Given this list of marker genes MAP7, SNRPF, DCTPP1, HLA-DPA1, CIITA, H2BC6, ADAM28, RPSA, ITGB7, SSR1, DAB2, DEPTOR, H1-3, CNN2, UPK3A, TAB2, PHB2, GNG7, CD207, UBE2L3, CCNB1IP1, CCR6, HMGA1, PPA1, RPS2, AXL, HDAC9, BCL2, SAMHD1, PEBP1, CD1C, PHF10, RPS3A, ZC3HAV1, FBLN2, HINT1, COL9A2, TMEM14A, TCAF1, AHNAK2, IL18R1, ATP5IF1, S100B (S100 calcium binding protein B), ARL4C, APMAP, NREP, RAB7A, H2AC13, GSN, FAM162A, GOLGA8A, SCRN1, EPB41L2, RPLP0, H3C8, PON2, H2AC14, PRKACB, CD226, CD59, CDC123, PPM1G, GRIP1, MAGEF1, BEND5, SPTBN1, RPL19, NUP210, SPATS2L, ALCAM, OFD1, RGS10, ZNF93, AFF3, ENSA, HLA-DQB1, PTTG1, BANK1, PPP1R16B, RPS23, MZT2A, SCD, BCL7A, RGS1, UCK2, SLC38A1, PDLIM1, WDR43, IL16, ZNF43, HADH, BIN1, ACTG1, PEA15, CCDC6, BLNK, EIF3K, FCER1A, SPINT2, HOXA9, HLA-DPB1, CLEC10A, H2AC16, TUBA1B, CNPPD1, BZW2, SLC9A7, CAPG, CD72, MICAL1, SEZ6L, CST7, PARP16, YWHAE, SLC2A1, DHRS3, HNRNPA0, PARM1, DENND1B, MOB3B, HMGN1, IL1R2, HIP1, RPL9, DTNA, NME1, MAP4K1, TRAP1 (NCBI Gene Id 51721), H4C11, SH3BP5, H2BC5, HLTF, TRIB2, FABP5, HLA-DRA, H2BC9, TENT5C, CCND2, CCT2, H4C3, NUCKS1, RPS6KA6, CST3, GOLGA8H, H2BC12L, SIGLEC6 (NCBI Gene Id 946), SNRPD1, CLIC2, SLC35F2, KLF8, HLA-DRB6, SUB1, APEX1, LRBA, FLT3, IL18 (NCBI Gene Id 3606), ARF6, SEPTIN6, SMARCA2, IL13RA1, EI24, RPS6, NDUFS8, H3C11, EVL, NET1, BASP1, PPP1R14B, CD22, H2BC10, RPS10P5, HNRNPC, IL2RG, CDK2AP1, KIT, H2BC8, TMEM109, RPS27A, BATF3, CD1E, TOB1 (NCBI Gene Id 10140), CD2, NDRG2, WEE1, H1-2, GOLPH3L, HERC2, HLA-DOA, H1-5, CCR5, UVRAG, SH3BP4, CCDC88A, H2BC7, AEN, TCTN3, GATM, IRF4 (interferon regulatory factor 4), LGMN, HLA-DOB, here is a description of the gene set: Genes down-regulated in comparison of monocytes versus myeloid dendritic cells (mDC). species: Homo sapiens Systems vaccinology has emerged as an interdisciplinary field that combines systems wide measurements and network and predictive modeling applied to vaccinology. Here we used the systems vaccinology approach to study the molecular mechanisms underlying th Human Gene Set: GSE29618_MONOCYTE_VS_MDC_DN from publication Nakaya HI, Wrammert J, Lee EK, Racioppi L, Marie-Kunze S, Haining WN, Means AR, Kasturi SP, Khan N, Li GM, McCausland M, Kanchan V, Kokko KE, Li S, Elbein R, Mehta AK, Aderem A, Subbarao K, Ahmed R, Pulendran B (PMID 21743478)